Given this list of marker genes Mga, Trim59, Nipsnap3b, Zfp275, Neurl3, Tmem200c, Arid4b, Socs2, Mylk, Il2rb, Metap1, Gphn, Zc3h12c, Crabp2, Lyar, Tet3, Adnp, Smu1, Gnpnat1, Sec24a, Tm9sf5, Ktn1, Max, Galnt2, Clec4a4, Psmd7, Tspan6, Zfp84, Drp2, Rac1, Unc5b, Med1, Pcdh9, Il23a, Thoc1, Trpc4, Glra2, Rbbp4, Smap1, Vps26c, Smndc1, Lonrf2, H2-Q10, Ash1l, Eif4g2, Mcl1, Stox2, Grm5, Meioc, here is a description of the gene set: Mouse Gene Set: MIR_6385 Genes predicted to be targets of miRBase v22 microRNA mmu_miR_6385 in miRDB v6.0 with MirTarget v4 prediction scores > 80 (high confidence targets). from publication Chen Y, Wang X (PMID 31504780) studied in species Mus musculus